Given this list of marker genes Ankrd23, Ankrd2, Obscn, Calm3, Actn2, Trim63, Capn3, Calm1, Calm2, Tcap (titin-cap), Ankrd1, Camk2d, here is a description of the gene set: Binding to titin, any of a family of giant proteins found in striated and smooth muscle. In striated muscle, single titin molecules span half the sarcomere, with their N- and C-termini in the Z-disc and M-line, respectively. Mouse Gene Set: GOMF_TITIN_BINDING studied in species Mus musculus